Given this list of marker genes PABPN1, ZCCHC12, MOS (NCBI Gene Id 4342), ABLIM1, ZNF281, PMAIP1, GALP, EXOSC2 (exosome component 2), ZNF667, PCDHGA11, KRT81, TBC1D31, CRHBP, EXOSC3, MATR3, IL11RA, CANT1, PIAS2, ARHGAP44, RECQL5, MCTS1, KCNK13, CDX4, COL21A1, OAZ3, PRR18, PIGZ, PCDHGB7, NRP2, TIGD3, GSPT2, WBP1L, TNPO3, DNM3, GTF2A1, SCG5, ZNF560, MAP7D3, VPREB3, SAP30BP, PFN2, ZNF582, CCDC34, SLC39A14, RPRD2, TMEM263, DHRS12, ARHGAP27, ZNF84, CDK8, TAFA4, CYP26C1, THBS4, MRPL9, here is a description of the gene set: We hypothesized that DNA methylation distributes into specific patterns in cancer cells, which reflect critical biological differences. We therefore examined the methylation profiles of 344 patients with acute myeloid leukemia (AML). Clustering of these patients by methylation data segregated patients into 16 groups. Five of these groups defined new AML subtypes that shared no other known feature. In addition, DNA methylation profiles segregated patients with CEBPA aberrations from other subtypes of leukemia, defined four epigenetically distinct forms of AML with NPM1 mutations, and showed that established AML1-ETO, CBFb-MYH11, and PML-RARA leukemia entities are associated with specific methylation profiles. We report a 15 gene methylation classifier predictive of overall survival in an independent patient cohort (p < 0.001, adjusted for known covariates). from publication Figueroa ME, Lugthart S, Li Y, Erpelinck-Verschueren C, Deng X, Christos PJ, Schifano E, Booth J, van Putten W, Skrabanek L, Campagne F, Mazumdar M, Greally JM, Valk PJ, Löwenberg B, Delwel R, Melnick A (PMID 20060365) species: Homo sapiens Human Gene Set: FIGUEROA_AML_METHYLATION_CLUSTER_2_UP Cluster 2 of aberrantly hypermethylated genes in blasts from AML (acute myeloid leukemia) patients.